The following is a description of a gene set: Any process that stops, prevents, or reduces the frequency, rate or extent of the chemical reactions and pathways resulting in the formation of MHC class II. Human Gene Set: GOBP_NEGATIVE_REGULATION_OF_MHC_CLASS_II_BIOSYNTHETIC_PROCESS studied in species Homo sapiens, and this is the list of marker genes: SPI1, TAF7, NFX1, IL10, PF4